Given this list of marker genes Zmiz1, Pias2 (protein inhibitor of activated STAT 2), Pias1, Ranbp2, Trim60, Zfp451, Egr2 (early growth response 2), Zmiz2, Nsmce2, Pias4, Trim28, Pias3, Cbx4, here is a description of the gene set: studied in species Mus musculus Mouse Gene Set: GOMF_SUMO_LIGASE_ACTIVITY Catalysis of the transfer of SUMO to a substrate protein via the reaction X-SUMO + S = X + S-SUMO, where X is either an E2 or E3 enzyme, the X-SUMO linkage is a thioester bond, and the S-SUMO linkage is an isopeptide bond between the C-terminal amino acid of SUMO and the epsilon-amino group of lysine residues in the substrate.